The following is a description of a gene set: species: Homo sapiens Any process that reduces the extent to which blood vessels can be pervaded by fluid. Human Gene Set: GOBP_NEGATIVE_REGULATION_OF_VASCULAR_PERMEABILITY, and this is the list of marker genes: FERMT2 (NCBI Gene Id 10979), ARHGAP35, ANGPT1, APOE, DDAH1, CEACAM1, SH3GL2, VEGFA, SLIT2, CLDN5, ADORA2A, PDE3A, PDE2A, PTPRJ, ADM, RAMP2, MIR23A, ABCC8, AMOT, AKAP12